The following is a description of a gene set: Genes having at least one occurrence of the motif SCTTTGAW in the regions spanning 4 kb centered on their transcription starting sites. This matches the TCF4 transcription factor binding site V$TCF4_Q5 (v7.4 TRANSFAC). studied in species Homo sapiens Human Gene Set: TCF4_Q5, and this is the list of marker genes: ELK3, SPO11, PANK2, THAP12, RALYL, FEM1C, COL18A1, SOX14, MYL3, RBM39 (RNA binding motif protein 39), SLC17A2, COLCA1, CDK1, PROX1, SLC22A8, PIM1, ACIN1, HOXA2, KCNQ1DN, CGN, ZIC1, NKD1 (NKD inhibitor of WNT signaling pathway 1, NCBI Gene Id 85407), NRP2, NEDD9, NIPAL3, ZFHX3, SCP2D1, DMXL1, MITF, EFNA4, BMP7, USP34, SLC6A10P, ANKRD28, EML4, KBTBD12, HOXD12, SYNPR, LINC03042, YARS1, NCDN, CYP2E1, SYTL2, CHD2, PCBP4, NFATC4, DCT, ABCD2, TCF7L2, ENPP5, RERE, TLL2, KRT85, PAX3, PRDM2, MAP4K5, CDC42BPB, HABP2, LIFR, ADAM9, ABHD2, PCM1, SGK3, NEUROD4, FOXP2, ELMO1, KCNJ13, BEST3, GPX2, LHX4, SP8, NLK, TGM1, CHRNA9, C14orf119, ARHGAP20 (Rho GTPase activating protein 20), EIF2B4, NEXN, GAB2, TFDP2, TAFA1, SLC26A9 (solute carrier family 26 member 9), ARID1A, ZBTB18, SCAMP3, ZMAT4, STEAP1B, STEAP1, FOXA1, CTHRC1, EIF4A2, HOXC6, MME, TGIF1, GPC4, MINDY1, TNFRSF19, MOSMO, PHC1, SNX17, ELF5, VIT, PRUNE1, CNTF, ZBTB20, FGF10, PCDH1 (NCBI Gene Id 5097), PRDM13, PCDH7 (protocadherin 7), HOXA10, NDC1, EYA1, TFAP4, CPNE1, KRTAP15-1, OGG1, ABCD1, SPOCK2, CUTA, PRKCB, G6PC1, NHLH2, SETD2, EBF2, FGF17, CUBN, TRIM33 (tripartite motif containing 33), TBXT, DOCK3, SIX4, TMEM256, SMO, PAM, PPARGC1A (PPARG coactivator 1 alpha), HOXD3, PANK1, SOX6, LRRTM3, MIDEAS, SLC7A8, CD27, MMP21, TM2D2, DACH1, EBAG9, ANKS1B, CKMT1B, STX1A, ZHX2, CDX1, SOX5, WNT6, UBE3A, PLSCR1, HAS2, HAPLN1, TRPM1, KRTAP11-1, HOXA11, TCF7, HOXB7, FGGY, MESP1, SH3RF2, NKX2-8, KRT23, CAVIN2, CBFA2T2, AP1G2, MYCL, ZIC4, MAP2K6, SHF, DQX1, RCOR2, SCG3, LINC00671, FBXW4, TSPAN2, DKK1, LPCAT3, CORO1C, CNTLN, NPPA, SLC17A6, ARK2N, IGDCC3, PCDH8, GABRB2, KY, SRRM4, UCP2, MARCHF10, EDN3, FERD3L, VXN, HOXB6, CHN2, HNRNPR, EIF4E (NCBI Gene Id 1977), MYH4, KLHDC8A, CLEC4D, AKAP1, WNT3, ADAMTS19, PPP2R5C, HOXC11, TBL1XR1, LIN28A, LYSMD1, CYTH3, HOXB4, NAV2, ASCL4, EYA2, SULT2A1, NFIX, PRRX1, WFIKKN2, AMMECR1L, TRMT1L, SGCD, LINC00310, TSHZ2, AGFG2, ZNF703, RPL23A, SORBS1, TCERG1L, PGAP1, NR4A3, RNF19B, ZEB2, ITGB6, SMAD1, SLC25A28, DLX1, KRT32, FST, LY6G6E, SCNM1, VAX1, AGAP1